The following is a description of a gene set: from publication Chen Y, Wang X (PMID 31504780) Mouse Gene Set: MIR_802_5P species: Mus musculus Genes predicted to be targets of miRBase v22 microRNA mmu_miR_802_5p in miRDB v6.0 with MirTarget v4 prediction scores > 80 (high confidence targets)., and this is the list of marker genes: Zfhx4, Scg2, Ankrd10, Tardbp, Hspd1, Slc7a13, Tmed9, Ermn, Fos (FBJ osteosarcoma oncogene), Gemin8 (gem nuclear organelle associated protein 8), Nmt2, Rwdd4a, Ctag2l2, Wdfy1, Glul, Zfp974, Dscam, Wnt10b, Chd9, Pigh, Matr3, Ahnak, Sntb2, Cep120, Khdrbs1, Lrrc28, Sox30, Rtl5, Ugdh, Neurl3, Macir, Sox6, Cyp7b1, Hnf1b, Pfdn1, Csgalnact1, Evi5, Slc25a53, Zfhx3, Slc2a3, H2az1, Sdc4, Hibadh, Nfe2l1, BC030500, Arhgef12, Erbin, Prorsd1, Gch1, Rbm6, Fbn2, Far2, Rora, Nek4, Nolc1, Fat1, Fam174a, Foxj3, Krtap6-1, Zmym2, Scamp1, Dipk2a, Rif1, Cenpw, Psmd2, Stox2, Map3k2, Smcr8, Dock4, Pafah1b1, Prkab1, Kmt2a, Ckap5, Obi1 (NCBI Gene Id 72486), Nhlrc2, Tufm, Ddx4, Cdc14b, Arl8b, Smtnl2, Rapgef4, Ppp2ca, Gnpnat1, Mkx, Nusap1, Snapc3, Neurl4, Etfrf1, Heg1, Ddit4, Pcsk5, Sgk2, Gcnt3, Snu13, Arid2, Lrp2, Ermp1, Gm14295, Atp6ap2, Acly, Zfp40, Bnc1, Srek1, Snx18, Acss1, Phf14, Rasgrp1, Cdca4, Cav1, Cyld, Nrk, Med13, Slc6a14, Kif4, Rnf11, Tasp1